The following is a description of a gene set: from publication Brideau CM, Eilertson KE, Hagarman JA, Bustamante CD, Soloway PD (PMID 20421412) species: Mus musculus List of genomically imprinted genes. Approximately 100 mouse genes undergo genomic imprinting, whereby one of the two parental alleles is epigenetically silenced. Imprinted genes influence processes including development, X chromosome inactivation, obesity, schizophrenia, and diabetes, motivating the identification of all imprinted loci. Local sequence features have been used to predict candidate imprinted genes, but rigorous testing using reciprocal crosses validated only three, one of which resided in previously identified imprinting clusters. Here we show that specific epigenetic features in mouse cells correlate with imprinting status in mice, and we identify hundreds of additional genes predicted to be imprinted in the mouse. We used a multitiered approach to validate imprinted expression, including use of a custom single nucleotide polymorphism array and traditional molecular methods. Of 65 candidates subjected to molecular assays for allele-specific expression, we found 10 novel imprinted genes that were maternally expressed in the placenta. Mouse Gene Set: BRIDEAU_IMPRINTED_GENES, and this is the list of marker genes: Igf2r, Igf2, Snrpn, Th, Tssc4, Zim1, Kcnq1, Cdkn1c, Tspan32, Magel2, Asb4, Ube3a, Nap1l5, Osbpl5, Dhcr7, Plagl1, Mkrn3, Atp10a, Drd1, Klrb1f (killer cell lectin-like receptor subfamily B member 1F), Peg3, Slc22a18, Scin, H19, Airn, Calcr, Phlda2, Qpct, Gnas (GNAS complex locus), Grb10, Art5, Peg10, Cmah, Apoc2, Rb1, Snurf, Ndn, Gatm, Tnfrsf23, Slc22a3, Slc38a4, Pon2, Mest, Sgce, Ascl2, Commd1, Ppp1r9a, Meg3, Mst1r, Mcts2, Impact, Pon3, Nnat, Peg12, Wt1, Cd81, Ins2, Cntn3, Copg2, Htr2a, Slc22a2, Ddc, Nap1l4, Fbxo40, Dcn, Sfmbt2, Dlk1 (delta like non-canonical Notch ligand 1), Rasgrf1